The following is a description of a gene set: from publication Liu F, Lei W, O'Rourke JP, Ness SA (PMID 16205643) studied in species Homo sapiens Genes down-regulated in MCF-7 cells (breast cancer) by overexpression of CMYB off adenovirus vector. The v-Myb oncoprotein encoded by Avian Myeloblastosis Virus is highly oncogenic, induces leukemias in chickens and mice and transforms immature hematopoietic cells in vitro. The v-Myb protein is a mutated and truncated version of c-Myb, a DNA-binding transcription factor expressed in many cell types that is essential for normal hematopoiesis. Previous studies suggested that two types of differences, DNA binding domain mutations and the deletion of a C-terminal negative regulatory domain were important for increasing the transforming activity of v-Myb. Here, we combined structure-function studies of the v-Myb and c-Myb proteins with unbiased microarray-based transcription assays to compare the transcriptional specificities of the two proteins. In human cells, the v-Myb and c-Myb proteins displayed strikingly different activities and regulated overlapping, but largely distinct sets of target genes. Each type of mutation that distinguished v-Myb from c-Myb, including the N- and C-terminal deletions, DNA binding domain changes and mutations in the transcriptional activation domain, affected different sets of target genes and contributed to the different activities of c-Myb and v-Myb. The results suggest that v-Myb is not just a de-repressed version of c-Myb. Instead, it is a distinct transcriptional regulator with a unique set of activities. Human Gene Set: LIU_CMYB_TARGETS_DN, and this is the list of marker genes: CYB5B, ATP6V1A, SOBP, SERINC3, SRRM2, RHOBTB3